Given this list of marker genes ZBTB20, NANS, KIF22, ARSK, GNPNAT1, here is a description of the gene set: An excessive concavity of the posterior surface of one or more vertebral bodies. Posterior scalloping of vertebral bodies studied in species Homo sapiens Human Gene Set: HP_POSTERIOR_SCALLOPING_OF_VERTEBRAL_BODIES